The following is a description of a gene set: studied in species Mus musculus Mouse Gene Set: REACTOME_TRANSCRIPTIONAL_ACTIVITY_OF_SMAD2_SMAD3_SMAD4_HETEROTRIMER Transcriptional activity of SMAD2/SMAD3:SMAD4 heterotrimer, and this is the list of marker genes: Tgif2, Mapk1, Smad7, Ube2d1, Parp1, Cdk8, E2f4, Uba52rt, Wwtr1, Sp1, Hdac1, Tfdp1, Ccnc, Atp1b4, Furin, Mapk3, Rbl1, Nedd4l, Skil, Rnf111, Cdk9, Ccnt1, Ski, Ube2d3, Ubb, Ncor2, E2f5, Smurf2 (SMAD specific E3 ubiquitin protein ligase 2), Rps27a, Men1, Ubc, Tgif1, Ppm1a, Ccnk, Smad3, Uba52, Smad4, Usp9x, Ccnt2, Smad2